Given this list of marker genes Slc7a11, Abcc1, Slc15a2, Abcc4, Slc13a3, Slc25a40, Slc25a39 (solute carrier family 25, member 39), Gja1, Abcc5, here is a description of the gene set: studied in species Mus musculus The directed movement of a tripeptide across a membrane by means of some agent such as a transporter or pore. A tripeptide is a compound containing three amino acids linked together by peptide bonds. Mouse Gene Set: GOBP_TRIPEPTIDE_TRANSMEMBRANE_TRANSPORT